Given this list of marker genes P3H4, RGS13, CD69, RETREG3, ASGR1, CXCL8, HIPK3, CABYR, SLC17A4, RPS6KB1, FGF12, NSDHL, CDKL3, SLC16A6, CXCL13, VAPB, RTCA, ST7, HIGD2A, PI4KA, APC, TYMS (thymidylate synthetase), TNNC1, NR1H2, PTAFR, CCNA2, TCF12 (transcription factor 12), FTSJ1, PAM, PLPP1, STOML1, LILRA4, DUSP2, SPTA1, SOD3, NAE1, IGF1R, DAO, RHOH, ADGRG1, MMP15, RCC1, DNM2, COL3A1, STOML2, RUNX1T1, PRR4, COL1A2, DCLK1, INPP1, GRIP1, CTRB1, CCK, ADSS2, MECOM, CNKSR1, FILIP1L, CYP4F8, DHX8, C5, CXCL12, TMEM126A, ELOB, ERBB3, POLE, SLC25A46, LAMTOR5, MLLT10, GRIK1, PIK3CB (NCBI Gene Id 5291), DHRS9, ENTREP1, RPH3AL, AADAC, ISCU, GLIPR1, CTBP1, SEMA3F (semaphorin 3F), CYP1B1, ATP2A2, ALG3, HLA-DPA1, GNAI1, RREB1, DDB2, TOP2B, CDK5R2, ECI1, LIMA1, TMEFF2, TAP2, NR4A2, GFUS, SRD5A1, SAE1, NPR3, ACYP1, NFAT5, NREP, CCNI, XK, GPR161, ADAM3A, TBL2, ETV4, RYR3, TIMM17A, TLX2, TAOK2, BRAF, S1PR1, SLC23A2, BMP6, AKAP5, SLC25A6, ALDH5A1, LLGL2, AMT, TAC1, DIO1, SLC3A2, TFAM, NECTIN1, UBN1, CCNA1, RNF4, GZMA, ADRA2C, PMAIP1, HMGA2, ZMYND10, WIF1, RAB35, JUN, TNFRSF17, UBE2I, CHST5 (NCBI Gene Id 82922), CNN2, DCAF7, EGR2, QDPR, MAP2K4, UBL3, PTN, CSF1, CASC3, LHFPL6, ZNF263, MMP17, ZNF32, SST, RPGR (retinitis pigmentosa GTPase regulator), CAPN3, UBE2D4, CD7, BST2, GRIN1, TMED10, KYAT1, ETV6 (ETS variant transcription factor 6), SSBP2, OAZ2, PNPLA6, IRS2, MARS1, PTK2, MAGED2, CPA1, FCN1, RAB33A, FGFR1, DMD, BCR, CAMP (NCBI Gene Id 820), GATA2, TNC, CCL14, ABCB9, TARDBP, CSE1L, BRDT, CAP1, FBXL2, EPS15L1, BCAS2, MT3, ZNF219, ADIRF, PIP4K2A, TNFSF10, PCSK6, GTF2E2, SMCP, ARID5A, MRPS10, NUDC, THPO, CD72, GRB2, MMP13, FAM50B, RFX3, TLE1, HLTF, IKZF1, DCTN1, ART4, SLC39A1, ABCB6 (ATP binding cassette subfamily B member 6 (LAN blood group)), here is a description of the gene set: from publication Rizki A, Weaver VM, Lee SY, Rozenberg GI, Chin K, Myers CA, Bascom JL, Mott JD, Semeiks JR, Grate LR, Mian IS, Borowsky AD, Jensen RA, Idowu MO, Chen F, Chen DJ, Petersen OW, Gray JW, Bissell MJ (PMID 18316601) Human Gene Set: RIZKI_TUMOR_INVASIVENESS_3D_UP A crucial step in human breast cancer progression is the acquisition of invasiveness. There is a distinct lack of human cell culture models to study the transition from preinvasive to invasive phenotype as it may occur spontaneously in vivo. To delineate molecular alterations important for this transition, we isolated human breast epithelial cell lines that showed partial loss of tissue polarity in three-dimensional reconstituted basement membrane cultures. These cells remained noninvasive; however, unlike their nonmalignant counterparts, they exhibited a high propensity to acquire invasiveness through basement membrane in culture. The genomic aberrations and gene expression profiles of the cells in this model showed a high degree of similarity to primary breast tumor profiles. The xenograft tumors formed by the cell lines in three different microenvironments in nude mice displayed metaplastic phenotypes, including squamous and basal characteristics, with invasive cells exhibiting features of higher-grade tumors. To find functionally significant changes in transition from preinvasive to invasive phenotype, we performed attribute profile clustering analysis on the list of genes differentially expressed between preinvasive and invasive cells. We found integral membrane proteins, transcription factors, kinases, transport molecules, and chemokines to be highly represented. In addition, expression of matrix metalloproteinases MMP9, MMP13, MMP15, and MMP17 was up-regulated in the invasive cells. Using small interfering RNA-based approaches, we found these MMPs to be required for the invasive phenotype. This model provides a new tool for dissection of mechanisms by which preinvasive breast cells could acquire invasiveness in a metaplastic context. species: Homo sapiens Genes up-regulated in three-dimentional (3D) cultures of preinvasive (S3-C) vs invasive (T4-2) breast cancer cells.